Given this list of marker genes PRKCD, LAT, IKZF3, CD28, TRAC (T cell receptor alpha constant), DEF6, TET2, ITK, PIK3R1, MAGT1, TNFRSF9, STK4, TOM1, PGM3, CD27, here is a description of the gene set: studied in species Homo sapiens Persistent EBV viremia Human Gene Set: HP_PERSISTENT_EBV_VIREMIA Persistent presence of Epstein-Barr virus in the blood.